The following is a description of a gene set: studied in species Homo sapiens Any process that modulates the frequency, rate or extent of response to endoplasmic reticulum stress. Human Gene Set: GOBP_REGULATION_OF_RESPONSE_TO_ENDOPLASMIC_RETICULUM_STRESS, and this is the list of marker genes: RNFT1, ATXN3, MBTPS2, AKT2, BCL2L1, TMX1, NR1H2, MAGEA3, UFL1, HSPA1A, ATF6B (activating transcription factor 6 beta), SVIP (small VCP interacting protein), SIRT1, BOK, WFS1, AKT1, PIK3R1, OPA1, USP14, TXNDC12 (NCBI Gene Id 51060), LRRK2, STUB1, UBXN2A, BAX, BFAR, PARK7, NFE2L1, HYOU1, NCK2 (NCK adaptor protein 2, NCBI Gene Id 8440), TMEM259, SGTA, PPP1R15B, AGR2 (NCBI Gene Id 10551), SERINC3, FICD, XBP1 (X-box binding protein 1), GRINA, NFE2L2, MANF, RNF185, DAB2IP, NCK1, NUPR1, BBC3, ALOX5, DDIT3, ERP29, PMAIP1, UBXN1, HERPUD1, TMEM33, USP19, SELENOS, RNF183, CLU, USP13, CAV1, PRKN, BAK1, FCGR2B, PTPN2, ABCA7, COPS5, ATF6, LPCAT3, USP25, UBQLN1, HSPA5, IKBKG, EIF2AK3, PPP1R15A, TMBIM6, PTPN1, AKT3, NR1H3, ERN1 (NCBI Gene Id 63433), CREB3, APP, CREBRF, AQP11, UBQLN2, PIGBOS1, ATXN3L, DDRGK1, RACK1, DNAJB9, BAG6, RNFT2, PDX1, CREB3L1, ATAD3A, BCL2L11, MIR199A1, SYVN1, BCAP31